The following is a description of a gene set: Protein repair species: Homo sapiens Human Gene Set: REACTOME_PROTEIN_REPAIR, and this is the list of marker genes: MSRB2, MSRB3, MSRA, MSRB1, PCMT1, TXN